The following is a description of a gene set: species: Homo sapiens Human Gene Set: GOBP_NEGATIVE_REGULATION_OF_RESPIRATORY_BURST Any process that decreases the rate frequency or extent of a phase of elevated metabolic activity, during which oxygen consumption increases; this leads to the production, by an NADH dependent system, of hydrogen peroxide (H2O2), superoxide anions and hydroxyl radicals., and this is the list of marker genes: INS, SLAMF8, DUSP10, RPS19 (NCBI Gene Id 8378), GRN, BCR